Given this list of marker genes RPS19, RMRP, LPIN2, ZNF699, KIF23, SAMD9L, MVK, here is a description of the gene set: Human Gene Set: HP_HYPOPLASTIC_ANEMIA studied in species Homo sapiens Anemia with varying degrees of erythrocytic hypoplasia without leukopenia or thrombocytopenia. Hypoplastic anemia